The following is a description of a gene set: Catalysis of the sequential cleavage of mononucleotides from a free 5' terminus of a DNA molecule. species: Homo sapiens Human Gene Set: GOMF_5_3_DNA_EXONUCLEASE_ACTIVITY, and this is the list of marker genes: MGME1 (mitochondrial genome maintenance exonuclease 1), PLD3, DCLRE1B, EXO5, PLD4, EXO1, APTX, DCLRE1A, DCLRE1C